Given this list of marker genes CLIC1, ADAM12, CAPZA1, NIBAN1, CDHR3, BARD1, BCL2, GCNT1, SLC16A6, GALM, ELAPOR1, IQGAP3, SLC25A24, TIFA, NTNG2 (netrin G2), RAB3D, SNTB2, IL2RB, MIB1, TIPARP, CTLA4, TXNDC16, PLG, ATAD2, ZCCHC18, DGKH, CDKN2B, CHN1, NCF4, IER5, IKZF4, IL10RB-DT, CDK19, PHACTR2, ESF1, MAP2K1, MAPKBP1, SAMD8, MUC6, MYB, HPGD, EIF3A (eukaryotic translation initiation factor 3 subunit A), B3GALT2, ATP1B1, IRS2, ZNF80, OPTN, VCPIP1, ANXA5, SURF4, ELL2, B3GNT5, DNAJC18, SOD2, PIWIL4, ABCC1, TTC39C, SLCO3A1, GABARAPL1, FRMD4B, IRF4, LINC01734, PERP, TBK1, ATP8B2, CCR6, FAM43A, UTRN, C18orf54, PIAS3, CEP55, UCK2, MEOX1, CRTAP, IBTK, GOLGA8B, SLC16A1, MCCC2, FBXO3, GLCCI1, SKAP1, DOK2, RUBCNL, SGSH, SLC35G2, FUCA2, RBMS3, DYNLL1, CLDND1, ANXA2, KDSR, GPR174 (G protein-coupled receptor 174), PPP1R16B, RAB11FIP1, MGME1, B2M, PHKB (NCBI Gene Id 5257), HERPUD1, SMCHD1, USP48, DNAAF4, RALB, UGGT1, HSPA1A, F2RL2 (NCBI Gene Id 2151), CENPO, CPOX, KNL1, SLC25A46, IDS, IL12RB1, CDC42EP3, CBLL1, DENND10, CCDC50, FCHO2, PIK3AP1, KAT2B, SNX30, RDX (NCBI Gene Id 5962), SSH1, CTNNA1, CASP8, S1PR2, IL2RA, ADCY3, PDP1, PPP1R26-AS1, PTBP2, AHR, TAB2, ZSCAN9, REEP3, MEF2C (myocyte enhancer factor 2C), FYCO1, INHBC (NCBI Gene Id 3626), WDR47, PTPN7, BCL2L11, ATP2B4, GLB1, RNF32-DT, SLC7A5, NR4A2, SDC4, ANXA2P2, IKZF2, UTS2, MYBL1, IQGAP1, SOCS2, SKAP2, FYN, S100A4, TRAF5, MIAT, CD58, FAM91A1, RCHY1, LINC01012, CASP1, ANKS1B, EEF1AKMT3, ELOVL5 (ELOVL fatty acid elongase 5), TNFRSF1B, HDAC4, TUT7, GATA3, OIP5-AS1, MARCHF3, CEP128, SETD7, CORO2A, PEA15, RNF19A, RGS12, RORA, EPS15, DUSP5, GPR19, PLS3, SRGN, RBL1 (NCBI Gene Id 5933), RPL39L, TPRG1, FHIP2A, PARPBP, HLA-DRA, BUB1B, RAP1A, DNA2, ZFAND6, FGL2, BASP1, GLCE, SAMSN1, H1-3 (NCBI Gene Id 3007), CST7, here is a description of the gene set: from publication Mold JE, Venkatasubrahmanyam S, Burt TD, Michaëlsson J, Rivera JM, Galkina SA, Weinberg K, Stoddart CA, McCune JM (PMID 21164017) We compared differences in fetal and adult T cells by performing whole genome profiling on sort-purified T cells (naïve CD4+ and Treg cells) from human fetal specimens (18-22 gestational weeks) and adult specimens (age 25-40 years old). Fetal and Adult Naïve CD4+ T cells phenotype: CD3+CD4+CD45RA+CCR7+CD27+, Fetal and Adult CD4+CD25+ Treg phenotype: CD3+CD4+CD25bright Human Gene Set: GSE25087_TREG_VS_TCONV_ADULT_UP studied in species Homo sapiens Genes up-regulated in comparison of adult regulatory T cell (Treg) versus adult conventional T cells.